Given this list of marker genes TMEM202 (transmembrane protein 202), PPP4R2, MRO, YTHDF1, NAP1L1, NT5C1B, ILRUN, PAPPA (pappalysin 1), RUNX1T1, ACSL3, DUOX2, SFMBT1, QKI, SEMA6D, AFDN, TESK2, ZC3H12C, VGLL3, GALNT3, RALGAPB, ADGRL4, RAB26, ASAP1, CASD1, ZFP36L2, RTL3, VAPA, SCGB2A1, BMF, RFX7, TOMM70, ATAD2B, RORA, RASA1, RANBP17, GCNT1, DNAJC27, CFAP97, TWIST2, KLF11, ZIC2, PIGA, BCLAF3, KHDC3L (NCBI Gene Id 154288), MTRR, ILF2, PRCC, NCKAP1, TMEM132E-DT, ARPP19, ZNF337, COL19A1, EIF2S1, MMP8, SLC25A36, CREBZF, SLC25A3, DDX60L, SMC1B, PACRG, LDLRAD4, ETS1, HNRNPA1L2, S100A2, PABIR1, DCAF10, HYCC2, RND3, SLC4A7, MBD2, TTPA, CLDN11, PCYT1A, DLX3, CLOCK, SP3, SRR, XRN1, ATOSA, VSX1 (NCBI Gene Id 8198), GPATCH2, BRD10, MEIS2, TLDC2, PHTF2, HOPX, MSI2 (musashi RNA binding protein 2), STRN3, CHEK1, REPS2, AR, ARPIN (actin related protein 2/3 complex inhibitor), BACH2, SUZ12, SIRT3, CLEC1A, CFAP206, ARGLU1, SYT14, ARID4B, CTDSPL2, ZNF721 (NCBI Gene Id 441003), SLC10A7, NRBP2, CDKL5, RABGAP1L, VAMP7, ANKRD17 (ankyrin repeat domain 17), RTTN, PRKAA2, JARID2, SCAND3, CASP3, RSU1, RAD50, MGAT4A, RAD51B, PRDM11, CHST9, ZSCAN4, NR1H4, TRMO, TTBK2, EDEM3, RAB30, PPP2R2C, PAPOLA, GAREM1, SNAP25, TBC1D4, PCDHB5, PCBP2, AFF4, ANKS1B, SPOCK3, FCHSD2, NRAS, BTF3L4, TMPO, SGIP1, ZNF706, CLCN3, HMG20A, FAM9A, PLS3, MSL2, GAN, TNKS2, SNRNP70, CAPZA1, PCDH9, TRPC3, PPP1CC, FAM8A1, MPV17, ZNF619, SOX17, SRSF10, BLOC1S6, SREK1IP1, TCP11L1, FAM9C, NIPBL, DCAF5, CALCRL, CACNB4, FRMPD2 (NCBI Gene Id 414180), TBC1D30, NMU, DCAF17, AKR1D1, PACRGL, JPH1, FOXC1, LRATD2, ELK4, CALM2, ZNF805, ATG2B, ZBTB11, TXNRD1, RDX, SEMA4D, here is a description of the gene set: Human Gene Set: MIR421 Genes predicted to be targets of miRBase v22 microRNA hsa-miR-421 in miRDB v6.0 with MirTarget v4 prediction scores > 80 (high confidence targets). from publication Chen Y, Wang X (PMID 31504780) species: Homo sapiens